The following is a description of a gene set: Mouse Gene Set: REACTOME_ESTROGEN_BIOSYNTHESIS Estrogen biosynthesis studied in species Mus musculus, and this is the list of marker genes: Hsd17b11, Akr1b10, Akr1b7, Hsd17b2, Cyp19a1, Hsd17b1, Akr1b8, Hsd17b14